Given this list of marker genes SMAD7, NUAK2, HES1, LIF, GADD45B, CSRNP1, ID4, BHLHE40, GADD45G, IL6, MAP3K14, JUNB, RASL11B, KLF10, IER5, ID2, EGR2, HBEGF, SPSB1, FBLN2, SPATA13 (NCBI Gene Id 221178), SNAI1, CDK5R1, SERPINE1, SLC20A1, PTGS2, NR4A1, ID1, ZMIZ1, FGF18, IER3, EGR3, WNT9A, here is a description of the gene set: Transforming growth factor beta (TGF-beta) and platelet-derived growth factor A (PDGFAlpha) play a central role in tissue morphogenesis and repair, but their interplay remain poorly understood. The nuclear factor I C (NFI-C) transcription factor has been implicated in TGF-beta signaling, extracellular matrix deposition, and skin appendage pathologies, but a potential role in skin morphogenesis or healing had not been assessed. To evaluate this possibility, we performed a global gene expression analysis in NFI-C(-/-) and wild-type embryonic primary murine fibroblasts. This indicated that NFI-C acts mostly to repress gene expression in response to TGF-beta1. Misregulated genes were prominently overrepresented by regulators of connective tissue inflammation and repair. In vivo skin healing revealed a faster inflammatory stage and wound closure in NFI-C(-/-) mice. Expression of PDGFA and PDGF-receptor alpha were increased in wounds of NFI-C(-/-) mice, explaining the early recruitment of macrophages and fibroblasts. Differentiation of fibroblasts to contractile myofibroblasts was also elevated, providing a rationale for faster wound closure. Taken together with the role of TGF-beta in myofibroblast differentiation, our results imply a central role of NFI-C in the interplay of the two signaling pathways and in regulation of the progression of tissue regeneration. species: Mus musculus Human Gene Set: PLASARI_TGFB1_TARGETS_1HR_UP from publication Plasari G, Calabrese A, Dusserre Y, Gronostajski RM, McNair A, Michalik L, Mermod N (PMID 19752192) Genes up-regulated in MEF cells (embryonic fibroblast) upon stimulation with TGFB1 for 1 h.